The following is a description of a gene set: studied in species Homo sapiens Neighborhood of RRM1 Human Gene Set: GNF2_RRM1 Neighborhood of RRM1 ribonucleotide reductase M1 polypeptide in the GNF2 expression compendium, and this is the list of marker genes: NASP, EIF2S1, MCM3, SSRP1, TMPO, DLGAP5, SERBP1 (SERPINE1 mRNA binding protein 1), GINS1, RRM1, ASPM, MCM2, MCM7, H2AX, GINS2, NDC80, HMMR, MRPL35, RRM2, PRIM1, SMC4, CDCA8, CKS2, KIF14, NUP37, SNRPD1, HAT1, VRK1, NUSAP1, MCM5, CHCHD3, CCNB2, SHCBP1, MSH2, CENPE, DHFR, FH, MT1JP, SLBP, DTL, FEN1, FOXM1, RAN, CENPF, PCNA, SMC2, BIRC5, CDK1, CENPM, PAICS (phosphoribosylaminoimidazole carboxylase and phosphoribosylaminoimidazolesuccinocarboxamide synthase), MCM6, TTK, FANCI, CCT6A, UBE2C, CDC20, TCP1, PA2G4 (proliferation-associated 2G4), MELK, MCM4, GMNN, E2F8, AURKB, RAD51AP1, ZWINT, RFC4 (NCBI Gene Id 5984), PRC1, USP14, KIF11, DTYMK, AURKA, PTGES3, ANP32E, METAP2, TYMS, MKI67, RFC3, PLK4, TOP2A, PCLAF (NCBI Gene Id 9768), HNRNPAB, CCNA2, SNRPG, HMGB2, BUB1B, PSMD14, KIF18B, RACGAP1, PCCB